Given this list of marker genes PNKP, KCNT2, COG2, LONP1, WDR45B, SCN2A, PIGQ, PIGA, MTOR, MAPK10, HID1, ARHGEF9, NSF, GRIA2, OTUD7A, HNRNPU, CACNB4, CACNA1B, KCNH5, CHD2, PRRT2, DMXL2, COG3, PIGW, KCNA1, KDM5C, TRIM8, GABRB3, CUX2, PSAP, SLC32A1, GLUL (glutamate-ammonia ligase), CENPE, ATP6V0A1 (ATPase H+ transporting V0 subunit a1), GRM7, CASK, FZR1, SCN1B, SQOR, GNAO1, FGF12, NGLY1, KCNQ2, PPFIBP1, GNB1, TUBA1A, SV2A (NCBI Gene Id 9900), PIK3CA, KCNT1, NEUROD2, VPS53, PACS2, DENND5A, CLCN3, PAFAH1B1, STX1B, PCDH12, GABRG2, PCDH19, NAPB, CEP85L, SLC25A12, SCN9A, GABRA1, PURA, SCN8A, ADNP, PLPBP, ARX, PPP3CA, RUSC2, PIGP, DPM1, CLCN4, ALG13, MECP2, PHACTR1 (phosphatase and actin regulator 1), SIK1, SCN1A, CTCF, CUL3, SLC38A3, ATP1A3, CNTNAP2, ATP6V0C, AKT3 (NCBI Gene Id 26068), ATP6V1A, SZT2, GRIK2, TBCD, CNPY3 (NCBI Gene Id 10695), KCNQ3, TSEN2, CPLX1, CACNA1C, DOCK7, SLC6A19, GRIN2A, D2HGDH, ARFGEF1, UFSP2, ST3GAL3, GABRA3, COQ8A, GRIN1, GABRA5, KCNC2, CDKL5, GRIA3, POMK, TBL1XR1, DNM1, LNPK, CACNA1A, KCNQ5, FBXO28, KARS1, TMEM147, PI4K2A, SLC1A2, HCN2, PTPN23, EEF1A2, WWOX, SYNJ1, MTHFS, NHLRC1, PLCB1, NEXMIF, MAST3, NACC1, TANGO2, MDH2, GABBR2, EN1, VPS50, RPL10, SATB1, PIGT, NECAP1, STXBP1, SLC25A22, ADGRV1, here is a description of the gene set: species: Homo sapiens A tonic seizure is a type of motor seizure characterized by unilateral or bilateral limb stiffening or elevation, often with neck stiffening. Human Gene Set: HP_TONIC_SEIZURE Tonic seizure